Given this list of marker genes ODAD4, GDF1, DNAAF5, CIROP, NODAL, DAW1, SMAD2, here is a description of the gene set: species: Homo sapiens Abdominal situs ambiguus An abnormality in which the abdominal organs are positioned in such a way with respect to each other and the left-right axis as to be not clearly lateralised and thus have neither the usual, or normal (situs solitus), nor the mirror-imaged (situs inversus) arrangements. Human Gene Set: HP_ABDOMINAL_SITUS_AMBIGUUS